Given this list of marker genes VPS36, PTPN23, MVB12B, STAM2, VPS37C, MVB12A, STAM, HGS, VPS37A, VPS37D, VPS28, UBAP1, TSG101, VPS25 (NCBI Gene Id 84313), SNF8, VPS37B, here is a description of the gene set: species: Homo sapiens Human Gene Set: GOBP_PROTEIN_TRANSPORT_TO_VACUOLE_INVOLVED_IN_UBIQUITIN_DEPENDENT_PROTEIN_CATABOLIC_PROCESS_VIA_THE_MULTIVESICULAR_BODY_SORTING_PATHWAY The process of directing proteins towards the vacuole that contributes to protein catabolism via the multivesicular body (MVB) pathway.